Given this list of marker genes Trps1, Psen2, G0s2, App, Ltb, Zswim2, Cd40lg, Agtr2, Fasl, Tnfsf15, Pycard, Srpx, Pdia3, Ripk1, Ppp1ca, Pmaip1, Hyal2, Gper1, Ltbr, Dedd2, Atf3, Dapk3, Sfrp1, Tnfsf11, Jak3, Tgfb2, Bid, Htra2, Pea15a, Faf1, Ptprc, Stk3, Traf2, Skil, Tlr6 (toll-like receptor 6), Ppp2r1b, Casp8, Agt, Lta, Nf1, Stk4, Tnf, Thbs1, Inhba, Bcl2l14, Tnfsf12 (tumor necrosis factor (ligand) superfamily, member 12), Cav1, Bcl10, Tnfsf10 (tumor necrosis factor (ligand) superfamily, member 10), Gsdma3, Tnfsf14, Mal, Siglec1, Itm2c, Bmpr1b, Fadd, Ppp2r1a, Wwox, Tnfrsf12a, Ret, Rbck1, Runx3, Cyld, Pml, Tlr4, Pak2, Ctnna1, Unc5b, here is a description of the gene set: Mouse Gene Set: GOBP_POSITIVE_REGULATION_OF_EXTRINSIC_APOPTOTIC_SIGNALING_PATHWAY Any process that activates or increases the frequency, rate or extent of extrinsic apoptotic signaling pathway. studied in species Mus musculus